The following is a description of a gene set: species: Mus musculus from publication Chen Y, Wang X (PMID 31504780) Genes predicted to be targets of miRBase v22 microRNA mmu_miR_743b_5p in miRDB v6.0 with MirTarget v4 prediction scores > 80 (high confidence targets). Mouse Gene Set: MIR_743B_5P, and this is the list of marker genes: Suco, Mrpl41, Ywhaq, Plagl2, Wsb1, Hdac7, Coq8a, Krtap6-5, Mctp2, Pdha1, Lnpep, Whrn, Mgat4a, Lbh, Zfp275, Plekhh1, Lrrc3b, Il21, Zmat3, Lamp3, Taf5, Uimc1, Tmem215, Ajap1, Tmem255a, Dennd5b, Smim14, Neb, Lypd6, Myadm (NCBI Gene Id 50918), Cers6, Slc38a4, Tsc22d1 (TSC22 domain family, member 1), Cyp4f14, Brd7, Kctd10 (NCBI Gene Id 97265), Or8b53, Taok1, Mrpl11, Afg1l (AFG1 like ATPase), Zfp729a, Mpc2, Map1b, Ncoa2, Ppp4r3a, Lenep, Sulf1 (sulfatase 1), Twist1, Ccdc85a (coiled-coil domain containing 85A), Eif1ad, Gimap6, Chuk, Map3k12, Cadps2, Mlh3 (NCBI Gene Id 30788), Cript, Trak2, Acbd3, Akt3, Gbp2b (NCBI Gene Id 677276), Prrt2 (proline-rich transmembrane protein 2), Marchf5, Lrsam1, Mtmr4, Tmem87b, Ces1g, AU018091 (NCBI Gene Id 245128), Cenpf, Trpd52l3, Ero1b, Arl16, Kif5c, Greb1l, Pag1, Mroh9, Btf3l4, Ywhab, Chd9, Fmn2, Tmed7, Mmd, Zc3h12c, Ptpn20, Traf6, Cask, Zfand6, Dgkk, Bnc2 (NCBI Gene Id 71498), Them4, Prickle2, Cul2 (NCBI Gene Id 75720), Klkb1, Slc25a32, Zbtb6, Atp1a3, Ftcd, Srsf1, Pgrmc1, Scarf1, Meis2, Etfdh, Zfp704, Srgap2, Hnrnpa0, Tubb2b, Unc5d, Arhgap29, Pcyt1a, Abi2, Med23, Gopc, Crkl, Api5, Hdac9, Mylk4, Wdr72, Osbpl11, Rnf14, Stxbp5l, Fut9, Acot1, U2surp, Grm8, Etnk2, Dusp11, Slc7a1, Cdc42se2 (NCBI Gene Id 72729), Glb1l, Zfyve26, Tmco1, Acy3, Uox, Glud1, Sel1l